Given this list of marker genes RPS3A, NLRP3, RPLP1, TUBB2A, MED17, NUP85, GSK3A, HMG20B, TLR7 (NCBI Gene Id 51284), SAR1B, CLEC4M, ARPC3, ZDHHC5, ANO10, IFNA13, RPL41, PACS1, RPS27 (ribosomal protein S27), H2AC1, PRKACG, POLR2H, H4C16, RPL19, RPL32, RPL36A, MGAT2, ST3GAL4, DOCK1, GNG2, RAB5B, PSMD6, PARP8, ITPR2, RPL35A, ERCC3 (ERCC excision repair 3, TFIIH core complex helicase subunit), HDAC1, NUP58, H2BC8, IGLV2-23, ZDHHC11, MAP2K7, CHMP6, GTF2F1, IGHV2-5, ARPC4, CTDP1, OSTC (oligosaccharyltransferase complex non-catalytic subunit), CNBP, CLTA, GRSF1, RANBP1, RBX1, H2AC7, BRK1 (NCBI Gene Id 55845), RPS15, TUBB, PRKACB, RPL26, IFNA14, GATAD2A, WIPF1, TUBA1B, RPS4Y1 (ribosomal protein S4 Y-linked 1), H2BC10, FXYD4, VPS37A, NT5E, ANO8, P2RX7, TLR1, VEGFA, RPS27L, NCOR1, CAV1, POLR2L, REST, ITGB1, IL1R1, PARP10, RCAN3, ARF1, RNF135, RAE1, RAB5C, ANO7, MED13, CALR, KPNA7, IGLV3-21, MAP2K4, CDK19, RIGI, NUP62, RPL7, PSMA7, PKLR, RPL13A, VAMP2, MAP3K7, NELFE, EEF1A1, CSNK2B, H4C3 (NCBI Gene Id 8364), HLA-A, IFNA8, IFNB1, PSMC6, MGAT1 (alpha-1,3-mannosyl-glycoprotein 2-beta-N-acetylglucosaminyltransferase), GTF2H1, PAK2, NOD2, IFNA17, WASL, IGKV4-1, IGKV3-20, G3BP1, PSMD2 (NCBI Gene Id 5708), RPS27A, EGFR, WASF3, H3C10, H3C12, IFNA21, MED30, IGLV3-27, IGKV1D-16, TUBAL3, SH3GL2, RIPK2, H4C6, HLA-G, NCKAP1, TUBB2B, GTF2A2, SEC24D, TAF9, CLTC, RPL37A, PPIA, XRCC4, RPS29, UBC, FNTB, AP1S3, RPL15, MYO10 (NCBI Gene Id 4651), GALNT1, MED7, SKP1, SLC25A5, IGLV6-57, SNRPF, IGKV3-11, GGT5, NUP93, RPS12, SUPT4H1, NOXA1, STAM2, SEC24A, SMAD4, NELFA, RUNX1, MAGT1, MOGS, PSMD3, VPS45, TAF13, MAPK14, WIPF2, SPCS2, GTF2B, H4C12, GNB5, DYNC1I2, ADCY9, H2BC26, RAB5A, VAMP1, PDCD6IP, ATP6V1H, IFNA1, GNAI2, ELOA2, ARPC1A, KPNB1, TAF3, PDCD1, IGHV3-53, G3BP2, GEMIN2, IGKV2D-40, PSMB7, TUBA3C, H4C14, POLR2D, IGLV2-14, IGKV1D-33, RPL37, IGKV1-12, H2AC8, AHCYL1, MED10, AP2M1, GNB2, GANAB, NMI, MED28, TGFB1, ARPC1B, H4C9, TXN, CUL5 (cullin 5), KDM1A, IGKV1D-39, H2AC19, H4C15, CTSG, TAB3, TMEM258, PARP16, WIPF3, NELFB (NCBI Gene Id 25920), PPP1CC, ADCY4, VPS25, RPL28, MAP1B, RPS15A, RPL34, RPLP2, VPS4A, NUP43, TUSC3, DDOST, CCNC (cyclin C), SDC1, ACE2, RPL23A, MTA2, GEMIN5, TAF1L, ELMO1, H2BC17 (NCBI Gene Id 8348), MED9, ATP1B2, NCBP1, LARP1, MET, HSPG2, NCKIPSD, GNG7, CASP1, CXCR4, ST6GALNAC4, PSMD12, SMN1, RPL36, IGKV3D-20, ANO6, MED8, IGKV1-39, CUL3, CSNK2A1, IGLC3, NCL, IGHG2, PSMA6, TUBB3, RPL6 (ribosomal protein L6), H2AC4, H3C11, AP2S1, ABI1, IGHG1, VPS33B, ATP1A2, NPIPB3, MED1, TBK1, ATP1B3, RNF213, H3C15, IMPDH2, OST4 (oligosaccharyltransferase complex subunit 4, non-catalytic), FXYD2, WASF2, RPL10, CREB1, TUBA4A, SYK, AP1B1, SUPT16H, IFNA4, PSMC1, GNAS, RPS16, NOX1, H2BC15, NUP153, H3C1, IPO5, S1PR1 (sphingosine-1-phosphate receptor 1), DYNLL1, MAPK3, SEC11A (SEC11 homolog A, signal peptidase complex subunit), VPS41, PSMD11, PRMT1, FXYD3 (FXYD domain containing ion transport regulator 3), PIK3C3, RPS13, MGAT4A, VPS37D (VPS37D subunit of ESCRT-I), SFN, GSDMD, ATG14, HSP90AB1 (NCBI Gene Id 3326), MNAT1, CD8B, EEF2, C3AR1, DVL1 (NCBI Gene Id 348497), H3C2, DYNC1LI2, MED19, RPS26, JAK1, NPM1, IGHG4, H4C5, RPL3, PDPK1, ACTR2, NUP133, DNAJC3, CCNT1, RPL10L, MED6, ARPC2, LTF (NCBI Gene Id 4057), SYT2, ACTR3, SEC11C, KPNA1, H4C13, NFE2L2, STING1, CDK7, BCL2L1, H2BC11, KPNA2, EED, PSMB3 (NCBI Gene Id 5691), GPC1, GNG4, IL1B, ADCY5, PPIH, SLC25A6, SAP18, SNRPE, MED26, GEMIN7, VCP, UVRAG, H2BC3, KPNA4, MED15 (NCBI Gene Id 51586), TXNRD1, IL17RA, IFNA10, CHMP3, RANBP2, ST3GAL1, SNRPB, SH3GL3, ENTPD1, SNRPD3, VPS16, DYNC1LI1, FKBP4, TUBB4B, FXYD6, PARP9, EDEM2, TOMM70 (translocase of outer mitochondrial membrane 70), NMT1, CD4, IGHD, ITPR1, CCNK, C3, AAAS, NUP210, RBBP7, IGKV1-16, ISG15 (ISG15 ubiquitin like modifier), IGHV4-59, GRB2, JUN, H2BC21, CYBA (NCBI Gene Id 1535), FCGR2A, NUP188, TAF15, RPL8, HBEGF, TRAF6, ST6GAL1, IGLV2-8, SDC2, ADRM1, FEN1, FKBP1A, RIPK1, PSMA1, NOD1, NHERF4, MED20, GNAT3, ISCU, DOCK2, PRKAR2A, SOS1, APP (NCBI Gene Id 351), IL17A, UBE2N, SUPT5H, KPNA5, FXYD7, MASP2, AP1M2, ENO1, ZDHHC2, VPS11, IL1A (NCBI Gene Id 3552), CBL, RPL7A, MED22, PARP1, VHL, TUBB8, PARP4, FURIN, NFKB1, LIG4, BCAP31, RPS4X, TAF4, PALS1, MAVS, H4C8, H2BC1, TAF6, H2BC7, PPP1CB, ANO4, HLA-C, CSNK2A2, SP1, MRC1, ADCY2, SPCS3, HMGA1, ANTXR1, CBLL1, HDAC2, PSMC4, SDC4, IGHV1-2, SAP30L, TUBA1A, WAS, GEMIN6 (NCBI Gene Id 79833), PPIG, TAF5 (TATA-box binding protein associated factor 5), ELOA, RPL38 (NCBI Gene Id 6169), RPS11, IGHV3-48, ITGA4, GEMIN8, TLR8, LY96, MED18, ABI2, RPL39, DDX20, IFIH1, NUP35, VPS28, PSMC3, GJA1, KPNA3, IGKV1-33, STX1A, PLCG2, AP2A1, PRKAR2B, CCNH, H2BC5, HLA-F, PGK1, DAD1, AP2A2 (NCBI Gene Id 25955), IGHV2-70, STT3A, TLR3 (NCBI Gene Id 7098), FUT8, CD3G, MVB12B, TXNIP, MYO1C, EPS15, ACTG1, VPS4B, RPL35, POLR2K, CDK8, SH3KBP1, HERC5, TLR9, PYCARD, CHD4, VAV1, ZDHHC20, SRC, POLR2E, ST3GAL2, IGHV3-33, RPS6, HCK, IGKV2D-28, RANGAP1, ANO5, RBBP4, ADCY8, NUP50, CYFIP2, HLA-B, MED14, NUP88, GNB3, IFNGR1, RPL22, ADORA2B, PSMC5, WASF1, SEM1, PATJ, CD14, CRK, ATP1A3, AKT1, TJP1, IGLV1-44, ANO2, TAF4B, H2BC6, H2AC18, TAF7, RPS24, MYH2, TUBB8B, YWHAG, TBL1XR1, NR3C1, H2BC9, H2AC20, UBA52, PRKCSH, CHMP5, HMOX1, MED27, GNAI1, H2AC12, TLR4, MAP2K3, BECN1, GPC4, H2AC17, IGLV7-43, AP2B1, HSP90AA1, SDC3, SEC24C, PIK3R4, IGKV1-17, TCEA1, TPR, TUBB4A, RPL11, XPO1, PTGES3, GNB4, STX1B, TRIM28, VPS18, MBL2, ATP1A1, RPLP0, RPN2, RPS19, IGLV3-19, BLNK, UBE2I, AP1G1, MED11, HSPA8, CX3CR1, SH3GL1, VPS37C, MYO5A, CRBN, SRPK1, NLRP12, BTK, DYNLL2, MED4, PSMA2, ADCY6, RPS9, SEH1L, FZD7, H2AC21, GTF2H4, CSNK1A1, H2BC4, FYN, TRIM25, STAT1, CREBBP, CD247, CHMP2B, H3C6, YWHAH (tyrosine 3-monooxygenase/tryptophan 5-monooxygenase activation protein eta), SMAD3, UBAP1, PSMC2, SAP30, CCNT2, RPS5, MYO9B, ST3GAL3 (ST3 beta-galactoside alpha-2,3-sialyltransferase 3), DAXX, SRPK2, RPL21 (ribosomal protein L21), BANF1, CTSL, IGKV3-15, TAB1, VAV2 (vav guanine nucleotide exchange factor 2), IKBKG, ITCH, SUZ12, DVL2, MTA3, NFKB2, ENTPD5, PSMD1, PSMB6, IFNA6, TLR6, CHMP4A, MED21, VAV3, H4C11, GNB1, ATP1B1, HSPA1A, RPS2, PSMD8, HLA-E, YES1, RPL31, MED25, PSMD13, TAF11, NUP42, NRP1, MVB12A, SFTPD, IFNAR1, PPP1CA, NCBP2, CD28, ELMO2, PSMD14, GEMIN4, CD79B, IGKV1-5, AP1S1, NUP54, SV2C, TAF9B, NUP37, ADCY7, PTK2, TRAF3, TAF1, IGHV4-34, RPS3, GPC6 (NCBI Gene Id 10082), GATAD2B, H2BC13, TMPRSS2, STAM, IRF3, CD163, ARID4B, YWHAE, ADCY3, PSMA5, TLR2, IGHV3-23, NOXO1, NFKBIA, H3C3, PSMB4 (NCBI Gene Id 5692), SNRPD2, PSTPIP1, PHF21A, VTA1, DUSP16, RNGTT, BAIAP2, POLR2G, RPL18A, SSRP1, RPS4Y2, IKBKE (NCBI Gene Id 9641), ITPR3, ANO9, GNAZ, H3C14, LYN, MGAT4C, MBD3, IRAK1, EZH2, ELK1, GNG8, RPL26L1, RPS18, VPS36, H3C7, H2AC13, AP1S2, IGKV2-28, PML, SIKE1, ELOC, TUBA3D, ZDHHC3, GTF2H5, CD79A, MAP2K2, AKT3 (NCBI Gene Id 26068), NUP160, IGLV1-47, GNG5, PABPN1, RPS25, JAK2, RAN, ELOB, RPL22L1, POLR2A, FGR, IL17F, SUDS3, GOLGA7, IGLV3-25 (immunoglobulin lambda variable 3-25), GTF2E2, SV2B (NCBI Gene Id 9899), H2AC11, H2AC14, IGKV5-2, IL18, IGHV4-39, PARP14, TSG101, SERPINE1, ZCRB1, ERCC2, HNRNPA1, TBL1X, CDK9, NOS2, NUP98, SEC23A, RPL27A, NCKAP1L, SPCS1, RNMT, IFNA7, P2RX4, UBE2L6, TAB2, NUP155, PSMD7, RPL18, TRIM4, RPS21, MGAT5, MED29, IGKV2-30, CEBPD, MASP1, POLR2B (NCBI Gene Id 7890), HDAC3, RIPK3, H2BC12, MAN2A1, BRD4, TUFM, DYNC1H1, CHMP4B (charged multivesicular body protein 4B), MAPK8, RCC1, CPSF4, RPL24, GTF2F2, ABL1, IGF1R, RPL13, DVL3, GTF2H2, VPS39, RPS28, IL6, MED24, IFNA2, CHMP4C, RPL23, CYSLTR2, RPS10, TUBA3E, H4C1, IGHV3-30, IGLC2, RPL39L, GPC5, WNT5A, NMT2, TBP, LCK, RPL12, FCGR3A, NELFCD, CHUK, CANX (calnexin), HAVCR1, CHD3, YWHAB, SV2A, PSMB5, PLK2, RPL14, TUBA8, CTNND1, NCOR2, TKFC, CRB3, ARID4A, H2BC18, IGHV3-11, GNG10, ROCK1, SUGT1, RPS17, PARP6, RPL17, PSIP1, HNRNPK, NUP205, ANO3, AKT2, POLR2I, SYT1, UBE2V1, CHMP1A, RPL29, MEFV, POLR2F, H3C4, ARPC5, RPL9, MED12 (mediator complex subunit 12), IRAK2, MED23, XRCC6, IGHV3-13, RPL3L, PSMB2, EIF2AK2, HGS, MED16, NEDD4L, MAP1LC3B, ROCK2, CALM1, NUP107, IGLV2-11 (immunoglobulin lambda variable 2-11), BRMS1, CBX1, GNGT2, IRF7, TYK2, IFNGR2, IGKV2D-30, ARIH1, TAF2, CYFIP1, CHMP7, RPS7, PTPN11, SNRPD1, H4C4, IGLV3-1, IL10, RPL5 (ribosomal protein L5), YWHAQ, GPC2, B2M, BTRC, TUBB6, RPL36AL, MAP2K6, PPIB, TRIM27 (tripartite motif containing 27), POLR2J, GNG13, SIGMAR1, PRKX, MGAT4B, SEC24B, LIG1, SUMO1, GTF2A1, RPS23, OAS2, IL17RC, VPS33A, SNF8, ANTXR2, CD9, ST6GALNAC3, RPL27, PLCG1 (phospholipase C gamma 1), PSMA4, TAF12, VPS37B, SFPQ, SNRPG, EP300, STAT2, UBB, DYNC1I1, MAPK1, ACTB, IFNA16, SEC13, IGKV1D-12, SMN2, RPN1, RHBDF2, GTF2H3, FCGR1A, GNG3, ANO1 (anoctamin 1), FAU, APOBEC3G, SNAP25, PRKACA, H2AC16, RCOR1, MAP2K1, AP1M1 (adaptor related protein complex 1 subunit mu 1), YWHAZ, GUCY2C, H3C8, GNG12, RPL30, TAF7L, PSMB1, ZBP1, IGHV1-46, CTNNB1, PRKAR1A, ADCY1, RPS20, KEAP1, NUP214, GGT1, DPEP1, ZDHHC9, CHMP2A, H2AC15, DDX5, RB1, RPL4, ELL, PTPN6, POM121, XRCC5, IGHV3-7, TAF10, TUBA4B, BST2, IGHV1-69, ADAM17, CCR5, AGRN, MED31, TUBA1C, IKBKB, IMPDH1, IGLV1-40, IFNA5, RPS8, GNGT1, H3C13, GTF2E1, CD209 (CD209 molecule), NCK1, GPS2, H2BC14, ZDHHC8, DPEP2, PRKAR1B, POM121C, MTA1, TUBB1, GNAI3, RAB7A, H4C2, PCBP2, RELA (NCBI Gene Id 5970), MED13L (mediator complex subunit 13L), RPL10A, GNG11, IGHM, RPSA, CDH1, IFNAR2, NDC1, JAK3, H2AC25, FXYD1, H2AC6, GSK3B, FNTA, MAN1B1, RAC1, SLC25A4, ATP1A4, IL6R, IGLV1-51, CDC42, POLR2C, GPC3, PSMA3, CORO1A, ST6GALNAC2, RPS14, CYSLTR1, MYH9, STT3B, COMT, here is a description of the gene set: Infectious disease studied in species Homo sapiens Human Gene Set: REACTOME_INFECTIOUS_DISEASE